The following is a description of a gene set: The negative regulation of a signal transduction pathway in response to a stimulus upon prolonged exposure to that stimulus. Human Gene Set: GOBP_NEGATIVE_ADAPTATION_OF_SIGNALING_PATHWAY studied in species Homo sapiens, and this is the list of marker genes: GIPR, APP, GRK2, APELA, ADM, ENTREP1, GTF2H2, CALCA, PLD2, APLN, GRK3, SAG, NECAB2, DRD3, DRD2, ARRB1, APLNR, GRM5 (NCBI Gene Id 2915, glutamate metabotropic receptor 5), ARRB2, ARR3, UBQLN2